Given this list of marker genes Hey1, Hey2, Bmpr1a, Srf, Rbpj, Eng, Dll4, Acvrl1, here is a description of the gene set: The process in which the anatomical structures of the dorsal aorta are generated and organized. The dorsal aorta is a blood vessel in a single-pass circulatory system that carries oxygenated blood from the gills to the rest of the body. In a single-pass circulatory system blood passes once through the heart to supply the body once. Mouse Gene Set: GOBP_DORSAL_AORTA_MORPHOGENESIS studied in species Mus musculus